Given this list of marker genes ZFAND3, BAG3, ENC1, DENND5A (NCBI Gene Id 23258), PNPLA8 (NCBI Gene Id 50640), CD4, ASH1L-AS1, TNFAIP3, TENM1, FYB1, GPX3, PELI2, ZNF711, ZNF211, FBXO7, GABARAPL1, SOX7, FBXO33, TRIM73, FNDC3B (fibronectin type III domain containing 3B), RBSN, MORC2-AS1, SPTY2D1, VIPR1, HYKK, ASAH1, ZXDB, BACH2, TXNIP, NFKBIZ, IRF2BP2, ZBTB4, MGAT4A, MAP4K4, FAM200B, HEG1, YPEL2, TRIB2, KCNA3 (potassium voltage-gated channel subfamily A member 3), ZDHHC11, HELZ, DUSP1, MAML2, RALGPS2, PASK, ERO1B, NSMCE3, PSTK, PDCD4-AS1, OVGP1, CCDC141, TNFSF8, GSE1, TTC28, SGK1, MYO1F, REM2, ATP8A1, STAG3L4, NEU4, FAM117A, KLF2, IL7R, BIN2, C9orf72, ATOSA, MYLIP, HABP4, TP53INP1, NLRP1, ARHGAP21 (Rho GTPase activating protein 21), BBIP1, SYNM, MINDY2, XYLT1, IRS2, FAM8A1, ITGA6, EFHC2, ST3GAL5, CGRRF1, LINC02604, SPTBN1, TRPS1, TPM2, PLCXD2, NDRG1, ALKBH7, GARS1-DT, ITPRIP, SGTB, FAM204A, FBXL5, ITGAM, ZFAND2A, KAT6A, YPEL5 (yippee like 5), ITPKB, CTBS, PCSK5 (proprotein convertase subtilisin/kexin type 5), PARP8, TSPYL4, NR4A2, SC5D, OSER1, EPHA4, TSC22D1, ITGA4, GADD45A, AK5, SOX4, ENPP2, VNN2, TTC32, C16orf54, FOSL2, INPP5A, VAV3, BMPR2, SECISBP2L, PDCL, WDR19, JMY, AQP3, VPS9D1, TSC22D3 (TSC22 domain family member 3), ZNF101 (NCBI Gene Id 94039), JUNB, GPRASP2, RBM33, ZNF10, TXK, YOD1, VWA5A, IL11RA, SORL1 (sortilin related receptor 1), SNX29, PTPRM, CNBD2, ZNF329, TOX, ABL2, FAM24B, PFKFB3, NAP1L5, ATXN1L, TSPAN32, EMB, PLEKHA1, CITED2, PTPN13, ARRDC3, CAPN2, PTGS2, USF3, LYZ, SENP7, CEP68 (centrosomal protein 68), TMEM131L, FHIT, ENSG00000280119, KIZ, KRT73, CPNE5, EVI2B, MXI1, ZNF8, GNPTAB, MEF2D, CRYBG1, ARMC12 (armadillo repeat containing 12), ABHD13, PCNX1, PPP3CC, ZNF805, MIR22HG, DNAJB9, ST6GALNAC3, LINC00938, RREB1, AMOT, TTN, TARS3, GABBR1, ERP27, UPP1, RASGRP2, UBASH3B, ST6GALNAC1, DPEP2, LCOR, PIK3R5, RNF10, TPRG1L, LPAR2, here is a description of the gene set: from publication Elo LL, Järvenpää H, Tuomela S, Raghav S, Ahlfors H, Laurila K, Gupta B, Lund RJ, Tahvanainen J, Hawkins RD, Oresic M, Lähdesmäki H, Rasool O, Rao KV, Aittokallio T, Lahesmaa R (PMID 20620947) Genes up-regulated in comparison of untreated CD4 T cells at 0 h versus the cells treated with IL4 and anti-IL12 at 24 h. Human Gene Set: GSE17974_CTRL_VS_ACT_IL4_AND_ANTI_IL12_24H_CD4_TCELL_UP studied in species Homo sapiens The aim of this dataset was to study in detail the transcription kinetics initiated by cytokine IL-4 in early differentiation of Th2 cells.